Given this list of marker genes NXT2, NXF1, NXF2, NXT1, NXF2B, NXF5, NXF3 (NCBI Gene Id 56000), here is a description of the gene set: A protein complex that contains two proteins (know in several organisms, including Drosophila, as NXF1 and NXF2) and is required for the export of the majority of mRNAs from the nucleus to the cytoplasm; localized in the nucleoplasm and at both the nucleoplasmic and cytoplasmic faces of the nuclear pore complex; shuttles between the nucleus and the cytoplasm. studied in species Homo sapiens Human Gene Set: GOCC_NUCLEAR_RNA_EXPORT_FACTOR_COMPLEX